The following is a description of a gene set: from publication Mebarki S, Désert R, Sulpice L, Sicard M, Desille M, Canal F, Dubois-Pot Schneider H, Bergeat D, Turlin B, Bellaud P, Lavergne E, Le Guével R, Corlu A, Perret C, Coulouarn C, Clément B, Musso O (PMID 27191501) species: Homo sapiens Human Gene Set: MEBARKI_HCC_PROGENITOR_WNT_UP_CTNNB1_DEPENDENT Methods: Liver progenitor cells were incubated in a WNT-enriched microenvironment for 72hrs (200 ng/ml mouse recombinant purified Wnt3A from R&D Systems). Gene pathways dependent on downstream _-catenin were studied by _-catenin knockdown with specific siRNA. Gene pathways blocked by extracellular SFRP-like Wnt inhibitors were studied by co-incubating cells with recombinant purified FZD8_CRD (300 ng/ml, from R&D Systems). Independent culture experiments performed in triplicate include untreated cells or cells incubated with scrambled siRNA or with _-catenin-specific siRNA or with FZD8_CRD, alone or in combination with Wnt3A. Transcriptome of human HepaRG hepatocellular carcinoma liver progenitors in responses to a WNT3A-enriched microenvironment and dissection of pathways dependent on _-catenin and/or blocked by the SFRP-like Wnt inhibitor FZD8_CRD., and this is the list of marker genes: COL5A2, ENO2, RNF43, PHLDB1, GOLGA8G, P4HA2, LFNG, LINC01173, MMP13, RBM24, SERPINE1, FBLIM1, IGFL1, CLDN2, CTHRC1, SLC38A3, CARMN, NREP, SLC12A8, CRISPLD2, CPEB1, LINC01705, IL1R1, MAGED4B, COL3A1, LINC03033, SH3GL1P2, CCDST, PRICKLE2, PKP3 (plakophilin 3), CXCL3, SLC26A2, TPM4, NOG, IHH, PCSK5, TYRP1, NANOS1, RDH10, SPARC, HAPLN1, ENSG00000227496, TCF7, ALDH7A1, CLIC3, ODAPH, LEF1, KANK1, CSF1R, CCDC80, NR2F1-AS1, ITGB4, IGFBP5 (insulin like growth factor binding protein 5), EPHB2, IGFL3, MMP7, ARID3A, EPYC, COL1A2, DLX5, GBP1, ARL4C, HMCN1, LCP1, PAMR1, F3, GCNT1, NKD2, ST6GAL2, PRR5L, LYPD1, IGF2BP3 (NCBI Gene Id 10643), RGCC, CLSTN2, DPT, SLC1A3, PI15, DACT1, COL1A1, BNC2, CSRP3, ENSG00000268460, CCN1, SRPX2, PITX2, EYA2, SEMA3C, KLHL4, PDLIM7, LUM, PRAG1